The following is a description of a gene set: Genes up-regulated in comparison of CD4 T cells treated with IL4 and anti-IL12 at 1.5 h versus those at 72 h. studied in species Homo sapiens The aim of this dataset was to study in detail the transcription kinetics initiated by cytokine IL-4 in early differentiation of Th2 cells. from publication Elo LL, Järvenpää H, Tuomela S, Raghav S, Ahlfors H, Laurila K, Gupta B, Lund RJ, Tahvanainen J, Hawkins RD, Oresic M, Lähdesmäki H, Rasool O, Rao KV, Aittokallio T, Lahesmaa R (PMID 20620947) Human Gene Set: GSE17974_1.5H_VS_72H_IL4_AND_ANTI_IL12_ACT_CD4_TCELL_UP, and this is the list of marker genes: IL7R, CD40LG, UBE2B, INO80, RNF38, FAM117B, EMC8, NATD1, PIGW, UBASH3B, ELL2, ZNF335, CHPF2, PUS3, BTBD19, BTG2, ATMIN, TRPS1, CWF19L1, PIK3CA, TCF7, CEBPZ, PRMT6, CLASRP, NAGPA, PSTK, RRP12, C12orf43, DENND6A, FYCO1, RALGAPB, PSMA3-AS1, TNFAIP3, FYTTD1 (NCBI Gene Id 84248), FBRSL1, NIPBL, CD69, SMCR8, CDK12, CSNK1G3 (NCBI Gene Id 1456), SLC9A8, B4GALT7, GRAMD4, UBE2D1, TRAPPC13, HCG18, PON2 (NCBI Gene Id 5445), PLK2, NR4A3, CKAP4, MAP3K2, ATXN3, NETO1, RRP15, C1orf198, USPL1, RBSN, RHOH, SNORD89, MX2, THAP7, MED13L, ZXDA, PELI2, PBXIP1, RRN3P1, EEIG1, KTI12, RNF103, NOP2, DPP8, EPB41L4A, RAB11FIP2, C6orf120, GPR89A, RABIF, SLC25A32, RNASEH1, RASA3, HIVEP1, LTV1, SDE2, CRTC3, CHMP7, CRK, IFNGR1 (NCBI Gene Id 3459), MOSMO, SEC62, GPM6B, ZNF641, CDC37L1, DTX3L, SHISAL2A, ENC1, CD83, MTMR6, ENTPD4, KDM6A, SLC35D1, CRYBG1 (NCBI Gene Id 6763), MNT, COQ10B, CTSO, IL23A, USP27X, CREM, RB1CC1, CDC14A, SESN3, SLC16A6, MTMR9, RELL1, MAST4, SERPINA1, URB2, SAMD4B, SH3RF3, INPP5K, ZNF791, NOL9, NUP98 (nucleoporin 98 and 96 precursor), ZNF200, JMY, MTUS1 (NCBI Gene Id 57509), NLRP1, ZNF350, TSPAN14, MOCS2, CLCN4, ANGEL2, RPP38, JADE2, HS3ST3B1, PLK3, SCARB2, NBN, CERK, ZNF552, MYLIP, PPBP, MGAM, ADAM29, SETD1B, KLHL24, MPP7, GRAMD2B, GEM, CCDC146, ADPRM, DDX27, DYNLL2, PAG1, ELMO2, PELI1, GOSR1, HIC2, NCOA5, S1PR1, CSRNP1, CRAMP1, SPATA2, TSPYL2, CCNY, PRDM1, CRACR2A, RBMXL1, TADA2B, YRDC, ZXDB, TP53INP1, CTPS1, DUSP2, TNFSF8, ZFX, MED19, ATXN7, STRIP1, TNF, DCTN6, SRSF6, LEPROTL1, FLNB, EXOSC6, KCNK15-AS1, ICE1, HSPBAP1, ELOA, ZNF37BP, CCR7, SLU7, HERC6, CSNK1D, TRMT6, RAPGEF6, R3HDM4, WDR48, FBXO28, MAML1